The following is a description of a gene set: Mouse Gene Set: GOBP_PROGESTERONE_SECRETION studied in species Mus musculus The regulated release of progesterone, a steroid hormone, by the corpus luteum of the ovary and by the placenta., and this is the list of marker genes: Fzd4, Mfn2, Inhba, Runx1, Gdf9, Retn